The following is a description of a gene set: Reactome Pathway: Protein repair part of: Metabolism of proteins species: Homo sapiens Reactive oxygen species (ROS) such as H2O2, superoxide anions and hydroxyl radicals interact with molecules in the cell causing damage that impairs cellular functions. Although cells have mechanisms to destroy ROS and repair the damage caused by ROS, it is considered to be a major factor in age-related diseases and the ageing process (Zhang & Weissbach 2008, Kim et al. 2014). ROS-scavenging systems include enzymes such as peroxiredoxins, superoxide dismutases, catalases and glutathione peroxidases exist to minimise the potential damage. <br><br>ROS reactions can also cause specific modifications to amino acid side chains that result in structural changes to proteins/enzymes. Methionine (Met) and cysteine (Cys) can be oxidised by ROS to sulfoxide and further oxidised to sulfone derivatives. Both free Met and protein-based Met are readily oxidized to form methionine sulphoxide (MetO) (Brot & Weissbach 1991). Many proteins have been demonstrated to undergo such oxidation and as a consequence have altered function. Sulphoxide formation can be reversed by the action of the methionine sulphoxide reductase system (MSR) which catalyses the reduction of MetO to Met. This repair uses one ROS equivalent, so MSR proteins can act as catalytic antioxidants, removing ROS. Methionine oxidation results in a mixture of methionine (S)-S- and (R)-S-oxides of methionine, diastereomers which are reduced by MSRA and MSRB, respectively. MSRA can reduce both free and protein-based methionine-(S)-S-oxide, whereas MSRB is specific for protein-based methionine-(R)-S-oxide. Mammals typically have only one gene encoding MSRA, but at least three genes encoding MSRBs. Although structurally distinct, MRSA and MRSB share a common three-step catalytic mechanism. In the first step, the MSR catalytic cysteine residue interacts with the MetO substrate, which leads to product release and formation of the sulfenic acid. In the second step, an intramolecular disulfide bridge is formed between the catalytic cysteine and the regenerating cysteine. In the final step, the disulfide bridge is reduced by an electron donor, the NADPH-dependent thioredoxin/TR system, leading to the regeneration of the MSR active site.<br><br>Beta-linked isoaspartyl (isoAsp) peptide bonds can arise spontaneously via succinimide-linked deamidation of asparagine (Asn) or dehydration of aspartate (Asp). Protein-L-isoaspartate (D-aspartate) O-methyltransferase (PCMT1, PIMT EC 2.1.1.77) transfers the methyl group from S-adenosyl-L-methionine (AdoMet) to the alpha side-chain carboxyl group of L-isoaspartyl and D-aspartatyl amino acids. The resulting methyl ester undergoes spontaneous transformation to L-succinimide, which spontaneously hydrolyses to generates L-aspartyl residues or L-isoaspartyl residues. This repair process helps to maintain overall protein integrity., and this is the list of marker genes: MSRA, MSRB2, MSRB3, TXN, MSRB1, PCMT1